Given this list of marker genes Fkbp10, Ero1a, Egln3, Jmjd7, Jmjd4, P4ha2, Ero1b, P3h3, P4ha1, Crtap, P3h4, Prdx4, Plod1, Jmjd6, P3h1, Plod3, Asph, Plod2, P4hb, Vipas39, Ogfod1, Egln2, Vps33b, P3h2, here is a description of the gene set: Mouse Gene Set: GOBP_PROTEIN_HYDROXYLATION species: Mus musculus The addition of a hydroxy group to a protein amino acid.